Given this list of marker genes Mgst3, Ltc4s, Alox5 (arachidonate 5-lipoxygenase), Lta4h, Prg3, Mgst2, Fcer1a, Pla2g5, Syk, Pla2g4a, Alox5ap, Ggt5, Abcc1, here is a description of the gene set: studied in species Mus musculus The chemical reactions and pathways resulting in the formation of leukotriene, a pharmacologically active substance derived from a polyunsaturated fatty acid, such as arachidonic acid. Mouse Gene Set: GOBP_LEUKOTRIENE_BIOSYNTHETIC_PROCESS